The following is a description of a gene set: Human Gene Set: HP_OVAL_FACE studied in species Homo sapiens Oval face A face with a rounded and slightly elongated outline., and this is the list of marker genes: SLC25A12, ADARB1, NFIX, CASK, SOX18, TP63, EXOC2, SH2B1, SPTBN1, PUF60, HYOU1, B3GALT6, TSPEAR, CNTN1, SPEN, EBF3